Given this list of marker genes TNR, CACNA1A, SCN1A, ATP1A2, WARS1, TRPV4, VWA1, HARS1, NOTCH2NLC, GNB4, HSPB3, GDAP1, COQ7, ANO5, ADSS1, SBF2, SPTLC2, DUX4L1, SNUPN, FBLN5, SPG11 (SPG11 vesicle trafficking associated, spatacsin), MORC2, LRP12, TIA1, NDRG1, MLIP, NEFL, GMPPB, FRG1, RYR1, SQSTM1, RTN2, SORD, FLNC, CADM3, TTN, DYSF, VCP, DDHD2, GIPC1, SMPX, SMCHD1, DUX4, LMNA, MME, RILPL1, PRRT2, JAG2, HK1, DNMT3B, here is a description of the gene set: Human Gene Set: HP_DISTAL_UPPER_LIMB_MUSCLE_WEAKNESS Reduced strength of the distal musculature of the arms. Distal upper limb muscle weakness studied in species Homo sapiens